The following is a description of a gene set: The process in which a relatively unspecialized immature germ cell acquires the specialized features of a mature female gamete. studied in species Homo sapiens Human Gene Set: GOBP_OOCYTE_DIFFERENTIATION, and this is the list of marker genes: RXFP2, SOHLH2, SOHLH1 (spermatogenesis and oogenesis specific basic helix-loop-helix 1), CCNB1, NPM2, REC8, MOS, PDE3A, DMRT1, BCL2, BNC1, YTHDF2, DAZL, YBX2, LSM14B, ZAR1, TDRD5, EREG, TRIP13, H3-3B, ZP3, ZFY, H3-3A, RPS6KA2, ZAR1L, IGF1, AURKA, CTNNB1, WASHC5, ANG, PPP2R1A, FIGLA (NCBI Gene Id 344018), TUT4, FUT6, RAB24, FBXO5, ATM, EDN1, NPR2, OOSP2, MEIOC, ZGLP1, EHMT2 (NCBI Gene Id 80735), DMC1, INHBB, TDRD6, WNT4, YTHDC2, LGR5, FOXL2, SIRT2, WDR77, DCAF13, KMT2D, TDRD7, CDC25B, PLD6, GDF9, TDRKH, BRCA2, NPPC, WEE2, BCAS2, EDNRA, TDRD1, TUT7, SHB, FOXO3, TUBB8